Given this list of marker genes KGD4 (alpha-ketoglutarate dehydrogenase subunit 4), ATP1B2, MAPT, HIF1AN, KATNB1, TBC1D16, CDCP2, RAD9A, NR1D1, BRWD1, KRTAP17-1, POPDC2, TRIM7, SLC26A9, RBM41, KPNA3, HIC2, GRK5, SH3GLB1, E2F1, PHKG2, EXTL1, SPOCK1, VRK2, PLXNA4, TENT4B, IL5RA, MS4A4A, ATCAY, TMEM86A, YBX2, UPRT, TMEM239 (transmembrane protein 239), ANP32E, RNF24, MRPL11, FNDC3A, STRADB, UBE2I, SAXO1, KIAA1191, ACOD1 (aconitate decarboxylase 1), UBE2Q1, TDRP, TXNDC5 (NCBI Gene Id 81567), PDSS2, HRH1, KCNH6, APLP2, DVL3, SSBP2, DHX33 (DEAH-box helicase 33), ZNF623, CAPZB (NCBI Gene Id 832), SLC9A8, PLIN3, CIBAR2, CPD, OSBP, PLEKHO2, POLE, FCGRT, RICTOR, PKMYT1, OGT, PELATON, RAB11A, ETV7, YWHAH-AS1, ANO10, GABBR2, EBI3, ACVR2B, GRIA3, PSAPL1, LRP8, PPP3R1, PIGS, MUL1, NPY1R, CCN2, PSD2, CLDN12, RTP1, SELENOF, PHTF2, KCNJ4 (potassium inwardly rectifying channel subfamily J member 4), WDR25, NXF1, SYNGR2, TBCK, MIP, ATP6V1F, KLF7, KLF6, ALDH3B2, PCDHB6, RCN3, MLX, TOP1, ZC3H13, TSKU, HDAC1, DPYSL3, MRPL22, CIITA, EARS2, SECISBP2 (SECIS binding protein 2), TRABD2B, EIF2AK4, TLX2, ASCL2, MAGI3, AAK1, here is a description of the gene set: Human Gene Set: MIR2467_5P species: Homo sapiens from publication Chen Y, Wang X (PMID 31504780) Genes predicted to be targets of miRBase v22 microRNA hsa-miR-2467-5p in miRDB v6.0 with MirTarget v4 prediction scores > 80 (high confidence targets).